Given this list of marker genes Ctr9, Dab2, Fn1, Myh9, Rtf1 (RTF1, Paf1/RNA polymerase II complex component), Hmga2, Setd2, Brd3, Map2k1, Mmp9, Mmp8, Mmp15, Vtn, Nodal, Itgav, Hnf1b, Lama3, Mmp2 (NCBI Gene Id 17390), Lamb3, Col12a1, Hsbp1, Gata6, Col8a1, Itga5, Mesp1, Leo1, Col5a1, Mixl1, Grb2, Inhba (NCBI Gene Id 16323), Nr0b1, Paf1, Macroh2a1, Col4a2, Ctnnb1, Eomes, Nanog, Pou5f1, Dkk1, Col6a1, Sox17 (NCBI Gene Id 20671), Col11a1, Col5a2, Cdc73, Sox2, Mmp14, here is a description of the gene set: studied in species Mus musculus Mouse Gene Set: GOBP_ENDODERMAL_CELL_DIFFERENTIATION The process in which a relatively unspecialized cell acquires the specialized features of an endoderm cell, a cell of the inner of the three germ layers of the embryo.